Given this list of marker genes Gja5 (NCBI Gene Id 70659), Pkp2, Strit1, Trpm4, Atp1a2, Pde4d, Casq2, Jup, Stc1, Ctnna3, Adrb1, Akap6, Atp1a1, Sri, Rangrf, Bin1, Pln, Dsg2, Ryr2, Akap9, Atp2a1, Cav3, Cacna1c, Ank2, Dsc2, Fxyd1, Myh7b, Cav1, Dlg1, Fgf13, Gata4, Adora1, Sumo1, Adcy10, Atp2a2, Scn5a, Kcnj2, Cacna1h, Dsp, Hcn4 (hyperpolarization-activated, cyclic nucleotide-gated K+ 4), here is a description of the gene set: studied in species Mus musculus Mouse Gene Set: GOBP_REGULATION_OF_CARDIAC_MUSCLE_CELL_CONTRACTION Any process that modulates the frequency, rate or extent of cardiac muscle cell contraction.